Given this list of marker genes JAK3, MYD88 (MYD88 innate immune signal transduction adaptor), RFXAP, MCM10, KLHDC8B, STAT1, ZAP70, IL2RG, MGAT2, BCL11B, WAS, TTC7A, RELB, PTPRC, RMRP, here is a description of the gene set: Human Gene Set: HP_IMPAIRED_LYMPHOCYTE_TRANSFORMATION_WITH_PHYTOHEMAGGLUTININ Impaired lymphocyte transformation with phytohemagglutinin species: Homo sapiens Normal peripheral blood lymphocytes, when stimulated by phytohemagglutinin (PHA) are cytotoxic for homologous and heterologous cells but not for autologous cells in monolayer culture. The cytotoxic effect is thought to be indicative of the immunological competence of the lymphocytes.